Given this list of marker genes GATA2, NTN1, TRIOBP, COL2A1, NECTIN1, PRRX1, GRXCR1, ATP8A2, TTC39C (NCBI Gene Id 125488), ATP6V1B1, PDZD7, SPARC, PTK7, ALDH1A3, SOX9 (NCBI Gene Id 6662), NEUROG1, MYO3A, PAX8, MYO15A, ITGA8, NHERF1, MAFB, CLRN2, CHD7, CLRN1, SCRIB, NR4A3, SPRY2, STOX1, DVL2 (NCBI Gene Id 1856), OTX1, ZIC1, LHFPL5, ATOH1, CHRNA10, SLC44A4, TIFAB, BCR, OTOP1, DLX6, PLS1, INSIG1, HOXA1, NECTIN3, ANKRD24, FGFR2, ZEB1, REST, DVL1, FZD3, EYA1, GRXCR2, TPRN, BLOC1S5, PROX1, KCNQ4, MYO3B, WNT3A, WDPCP, SOD1, POU3F4, TCAP, WHRN, FZD6, FGF8, MYO6, STRC, FOXG1, MYO7A, HESX1, CHRNA9, SEC24B, FZD2, LRIG1, EPHB2, FGF9, TECTA, COL11A1, CEP290, USH1C, TBX3, VANGL2, RAC1 (Rac family small GTPase 1), FGFR1, WNT1, SIX1, TBX2, FOXI1, DLX5, SLITRK6, PAX2, CTHRC1, INSIG2, SIX4, FRZB, CDH23, WNT5A, TFAP2A, HPN, HMX2, TBX1, KCNQ1 (potassium voltage-gated channel subfamily Q member 1), GBX2, SOBP, GRHL3, TMIE, LRIG3, FGF10, POU4F3, USH1G, DCANP1, HMX3, TBX18, GATA3, here is a description of the gene set: The process in which the anatomical structures of the inner ear are generated and organized. The inner ear is the structure in vertebrates that contains the organs of balance and hearing. It consists of soft hollow sensory structures (the membranous labyrinth) containing fluid (endolymph) surrounded by fluid (perilymph) and encased in a bony cavity (the bony labyrinth). It consists of two chambers, the sacculus and utriculus, from which arise the cochlea and semicircular canals respectively. Human Gene Set: GOBP_INNER_EAR_MORPHOGENESIS species: Homo sapiens